Given this list of marker genes KIFC2, KIF5B, KIF5A, KIF3B, KIF5C, KIF17, KIFAP3, here is a description of the gene set: The directed movement of a neurotransmitter receptor complex along microtubules in nerve cell dendrites towards the postsynapse. Human Gene Set: GOBP_ANTEROGRADE_DENDRITIC_TRANSPORT_OF_NEUROTRANSMITTER_RECEPTOR_COMPLEX studied in species Homo sapiens